The following is a description of a gene set: Genes up-regulated in plasmacytoid dendritic cell 7d vs 0d in young adults (18-50) after exposure to Fluarix/Fluvirin, time point 7D Human Gene Set: NAKAYA_PLASMACYTOID_DENDRITIC_CELL_FLUARIX_FLUVIRIN_AGE_18_50YO_7DY_UP from publication Nakaya HI, Wrammert J, Lee EK, Racioppi L, Marie-Kunze S, Haining WN, Means AR, Kasturi SP, Khan N, Li GM, McCausland M, Kanchan V, Kokko KE, Li S, Elbein R, Mehta AK, Aderem A, Subbarao K, Ahmed R, Pulendran B (PMID 21743478) studied in species Homo sapiens Here we have used a systems biology approach to study innate and adaptive responses to vaccination against influenza in humans during three consecutive influenza seasons. We studied healthy adults vaccinated with trivalent inactivated influenza vaccine (TIV) or live attenuated influenza vaccine (LAIV). TIV induced higher antibody titers and more plasmablasts than LAIV did. In subjects vaccinated with TIV, early molecular signatures correlated with and could be used to accurately predict later antibody titers in two independent trials. Notably, expression of the kinase CaMKIV at day 3 was inversely correlated with later antibody titers. Vaccination of CaMKIV-deficient mice with TIV induced enhanced antigen-specific antibody titers, which demonstrated an unappreciated role for CaMKIV in the regulation of antibody responses. Thus, systems approaches can be used to predict immunogenicity and provide new mechanistic insights about vaccines., and this is the list of marker genes: ZBED4, CFLAR, EPB41L3, KLHL28, ELP4, LILRA1, PIH1D1, HSD17B8 (hydroxysteroid 17-beta dehydrogenase 8), SFSWAP, ZMAT3, BRD3OS (NCBI Gene Id 266655), SEC14L1, CD22, TNFRSF10B, STX16, SPEN, EIF4A1, NMB, GADD45B, CARD8 (NCBI Gene Id 22900), TP53I3, UBXN4, ARNT, ZFP36L1, NCOR1, IL6R, APLP2, AKAP6, HIPK3, SCO2, TMPO, IGHM, MEF2C, DPP4, TNPO2, CEP135, LIMK2, H2AC18, FEM1B, POM121C, POM121, IGHG1, TASOR (transcription activation suppressor), DEDD, TRIM33, CTSO, NEAT1, IQGAP1, BACH1, RASA2, LRRC37A2, CRIM1, PLBD1, APEX2, PRKCA, PTGS2, PFN2, RALBP1, DHX40, RABGGTB, CD86, SRRT, COL9A3 (collagen type IX alpha 3 chain), IGHA1, SLC17A5, EEA1, KYNU, RGPD8 (NCBI Gene Id 727851), CALML4, IL10RB, LPIN1, AMMECR1, COTL1, VPS26C, SMAD2, TLE5, OAS3, ARRB2, WDFY3, SLC4A7, GPR52, LAIR1, AIFM1, CCNA2, STX17, PTPN12, SIK3, BLVRA, KPNA6, POLR2A, TLE4, RHOQ, KLF9, RAD21 (NCBI Gene Id 5885), CDC42EP3, TMUB2, SULT1A1, ZPR1, CENPO, RALGAPB, KRAS, NOLC1, SLC35D1, TNIP1, SZRD1, GNL3L, MTAP, IGHG3, CDC25A, UBA7, PPIA, PMAIP1, SLC12A3, KIF2A, SIGLEC6, MRPS18C, EYA3, STX5 (syntaxin 5), CD40, TAOK3, CLUAP1, SNX27, F11R, SULT1A3, CBLB, ATP5MC2, ISG20L2 (interferon stimulated exonuclease gene 20 like 2), SRSF11, TCOF1, WSB1, RHOB, PCBP2 (NCBI Gene Id 5094), IRF3, LGALS8, ATP10A, BAX, IPO5, DLG1, PDE4DIP, PSEN1, TIMP2, STX11, CD180, SULT1A4, NIPBL, MTSS1, TIMM10B, APAF1, HECTD3, EGR1, GABPB1, H2AC19 (NCBI Gene Id 723790), TNFSF12-TNFSF13, GLO1, ITSN2, TMEM135, PRP4K, DNAJB6, RGPD6, CTSZ, HEXIM1, SLC2A3 (NCBI Gene Id 94827), KRT86, CDHR5, SP4, GABBR1, RGPD5 (RANBP2 like and GRIP domain containing 5), IGHG4, CNOT4, TNFSF13, JUN, NRP1, TMCC1 (transmembrane and coiled-coil domain family 1), MYC, ZNF148, DENND10, MARCKS, ADAM28, KDM5B, FAR2, SCAF11, IPCEF1, IGHD, CAMSAP1, ZNF593, IGHV3-23, TMEM260, SLC2A14, RBMX, RRP9, HGSNAT (NCBI Gene Id 8119), SF1 (NCBI Gene Id 7536), DHX34, PSME3, ZGPAT, ADCK2, THBS1, PALM2AKAP2, ALDH5A1, GOLGA2, S100A2, PTK2, WASHC4, TRPS1, CRABP2, ZMYND8, RBM12B, ATF7IP, MAP3K7, PAK2, SAR1A, NTM, FOXO3, GGPS1, TFDP2, ARIH1, IGHA2, HBS1L, CD69